The following is a description of a gene set: This event has been computationally inferred from an event that has been demonstrated in another species.<p>The inference is based on the homology mapping from PANTHER. Briefly, reactions for which all involved PhysicalEntities (in input, output and catalyst) have a mapped orthologue/paralogue (for complexes at least 75% of components must have a mapping) are inferred to the other species. part of: Gamma-carboxylation, transport, and amino-terminal cleavage of proteins electronically inferred by orthology from the curated human pathway studied in species Mus musculus Reactome Pathway: Removal of aminoterminal propeptides from gamma-carboxylated proteins, and this is the list of marker genes: Gas6, Proc, F2, Pros1, Bglap2 (NCBI Gene Id 12097), Proz, F10 (NCBI Gene Id 14058), F9, F7